The following is a description of a gene set: Genes predicted to be targets of miRBase v22 microRNA mmu_miR_7210_3p in miRDB v6.0 with MirTarget v4 prediction scores > 80 (high confidence targets). Mouse Gene Set: MIR_7210_3P species: Mus musculus from publication Chen Y, Wang X (PMID 31504780), and this is the list of marker genes: Bcas2, Pank4, Gstt3, Tbc1d24, Hapln1, Zfx, Dbf4, Lingo2, Phkg1, H2-D1 (histocompatibility 2, D region locus 1), Uty, Jmjd1c, Ccdc162, Smarca2, Osmr, Slc24a2, Irgm1, Mkx, Mef2c (NCBI Gene Id 71350), Slc5a7, Zfp1008, Oprk1, Gadl1, Cpeb4, Gm5591, Tec, Csrnp3, Tnfrsf9, Muc4, Gopc, Usp6nl, Rtp1, Herc6, Slc35e2, Idh2, Tapbpl, Rnf138, Cop1, Exosc2, Gfra2, Churc1, Kcnk1, Map3k8, Kctd6, Cthrc1, Blzf1, Trim43b, Zfand5, Atp13a3, Tead1, Vma21, Yipf4, Rimoc1, Inpp5a, Pea15a, Plekhb2, H2-T23, Esp18, Ppp6r1, Slc25a53, Heph, A830018L16Rik, Gucy1a2, Unc80, Rock1, Pfkfb2, Wdr82, Ercc6, Dsg4, Sox18, Mef2a, Pum1, Dapk1, Larp4, Adamts19, Rabggta, Ets1, Alg14, Hcn1 (NCBI Gene Id 319874), Atpaf2, Stox2, Sftpa1, Cnot4, Trp53rkb, Smap1, Slitrk1, Wnt5a, Ugt2b36, Zbtb18, Aqp4, Irf9, Yod1, Cdkl4, Zc2hc1a, Ajap1, Treml2, Zfp26, Pola2, Hook3, Rab11fip1, Prkcd, Spire2, Gad2 (NCBI Gene Id 70758), 4930523C07Rik, Maml3, Ptbp3 (NCBI Gene Id 99962), Gata3 (GATA binding protein 3), Zfp608, Il7, Arhgef11, Ret, Fam149b, Kcnh5, Numb, Vamp2, Acvr2a, Brcc3, Lcorl (NCBI Gene Id 338482), Gpalpp1, Prss35, Satb2, Cacnb4 (calcium channel, voltage-dependent, beta 4 subunit), En2, Dazl, Cyp2e1, Isg20l2, Gulp1, Steap3, Nrf1, Cxcl15 (C-X-C motif chemokine ligand 15), Slc6a6, Galntl6, Nexmif, Prrx1, Pcdhb18, Ids, Slc4a10, Pmp22 (NCBI Gene Id 18858), Dusp7, Rspry1, Gon7, Trim2, Tbk1, Mat2b, Zfp516, Ppbp, Tet3, Mrpl9, Ogdh, Tbccd1, Skint11, Aldoart2, Rxrg, Chpt1, Stra6l, Nufip2, Zyg11b, Krt79, Hnrnpr, Zfp763, Adgrg3, Golt1a (golgi transport 1A), Fam3c, Gm11992, P3h3, Vezf1, Dmd, Lep, Hhip, Parg, Gas2l3, Sema3c, Sp1, Zfp935, Slc39a14, Spink5, Nipbl, Tyr, Dclre1c, Foxa2, Ncbp3, Tmem178b, Plcl1, Rai1, Pter, Abca8a, Itga2, Mdga2, Fam177a, Ehhadh, Recql, Dmrta2 (doublesex and mab-3 related transcription factor like family A2), Dnah5, Comt, Plagl1, Alcam (NCBI Gene Id 11658), Dnm1, Prdm1 (NCBI Gene Id 12142), Dync2i2, Mrtfa, Pde10a, Fam177a2, Padi4, Uba3, Btnl9, Rbm8a, Htr5a, Hbp1, Tnrc6b, Abhd13, Pbdc1, Nfib, Prag1, Creb5, Six6, Fech, Iyd, Eps8, Tmem26, Scn2b, Cplx2, Cxcl12, P2ry12 (NCBI Gene Id 73058), Bhmt, Cntn4, Wnk3, Larp1, Tent5a, Coq3, Bdnf, Stxbp5, Kpna4, Tspan2, Ap1b1, Loxl3, Phip (NCBI Gene Id 83946), Pus7, Zeb2, Syap1, Kalrn, Rpf1, Mrps33, Pdzd8, Ankrd42, Strn3